The following is a description of a gene set: studied in species Homo sapiens Human Gene Set: KEGG_MEDICUS_REFERENCE_NUCLEAR_EXPORT_OF_MRNA Nuclear export of mRNA. Pathway ID: N01152. Pathway type: Reference. Pathway class: nt06464 Amyotrophic lateral sclerosis. Pathway Definition from KEGG: (mRNA(nuclear)+CBP+ALY+SR+TAP+p15) -- (NPC+GLE1+DDX19B) -> (mRNA(cytoplasmic),CBP,ALY,SR,TAP,p15), and this is the list of marker genes: NUP58, NXT2, NCBP1, RANBP2, ALYREF, NXF1, NUP133, POM121, NUP35, NUP93, NUP43, GLE1, NUP155, NUP85, NUP160, NUP214, NUP205, NUP188, NUP62, NUP210, NUP37, SRSF7, SRSF3, NUP88, NDC1, NUP107, NXT1, DDX19B, NUP54, SEH1L